The following is a description of a gene set: The presence of multiple lipomas (a type of benign tissue made of fatty tissue). Human Gene Set: HP_MULTIPLE_LIPOMAS Multiple lipomas studied in species Homo sapiens, and this is the list of marker genes: MT-TS2 (NCBI Gene Id 8020), MT-TF, MT-TK, PTEN, MT-TP, ALX1, MSTO1, PRDM10, ZSWIM6, CDKN1A, PIK3CA, KRAS, FGFR1, MT-ND5, MEN1, MFN2, TBXT, GNA11, MT-TL1, CDKN2C, HEPACAM, CDKN1B, FUZ, CDKN2B, MT-TH, SPRED1, CCL2, VANGL2, ABCC6, VANGL1, LEMD3, ALX3, KCTD1, MT-TQ (mitochondrially encoded tRNA-Gln (CAA/G)), AKT1, AP2S1, BMPR1A, ENPP1, MT-RNR1, FLCN, APC